Given this list of marker genes TEX14, SEPTIN4-AS1, ENSG00000266100, RNU1-108P (NCBI Gene Id 106481957, RNA, U1 small nuclear 108, pseudogene), MIR4736, MIR142HG, SMIM36, PCTP, ARL2BPP8, COX11, ISCA1P3, MIR454, RNF126P1, MKS1, SNRPGP17, RN7SL716P, RNU6-1158P, RPL39P33, AKAP1-DT, HSF5, ENSG00000287337, EPX (NCBI Gene Id 8288), RPS2P48 (NCBI Gene Id 650055), AKAP1, SRSF1, RNVU1-34, MTCO1P40, C17orf67, SEPTIN4, TRIM37 (tripartite motif containing 37), CA10, OR4D1, RN7SKP94, RNU1-52P, OR4D2, MIR4729, RNU6-1249P, GARS1P1, COIL, RNU2-58P, HLF, SMG8, SUPT4H1, TSPOAP1, ANKFN1, LINC01982, SKA2, SCPEP1, ENSG00000289016, CUEDC1, TSPOAP1-AS1, MSX2P1, TMEM100, RN7SKP14, CCDC182, MIR301A, TOM1L1, PRR11, LINC02089, GDPD1, PPM1E, PRR11-AS1, MPO (myeloperoxidase), YPEL2, MIR3614, MIR142 (microRNA 142), RNU6-518P, SPDYE22P, RN7SL449P, STXBP4, KIF2B, SETP3, DYNLL2-DT (DYNLL2 divergent transcript), MRPS23, LPO, TRIM25, DGKE, MMD, RNF43, RAD51C, VEZF1, MTMR4, MSI2, DYNLL2, IGBP1C, ENSG00000263499, NOG, RNU7-134P, here is a description of the gene set: Human Gene Set: chr17q22 studied in species Homo sapiens